Given this list of marker genes MMP12, ACY1, CAPN2, PLAU, ENPEP, FOLH1 (folate hydrolase 1), MMP10, CPA3, KLK6, CTSB, ACE, PRSS8, ADAM9, MMP13, FAP, CPN1, NAPSA, MMP7, PRSS2, F2, PEPD, CPM, CTSS, FURIN, TPSAB1, MMP15, CTSW, C2, CTSL, OLR1, GZMB, LAP3, GZMA, BMP1, CTSK, C1S, MMP11 (matrix metallopeptidase 11), PSMB9, CPB2 (NCBI Gene Id 81954), CTSC, C1R, TMPRSS2, PROC, HPN, CTSD, F12, GZMK, CELA3A, PGC, CTSE, CFB, CASP4, CASP1, MST1, HP, UBD, PLG (NCBI Gene Id 90749), MMP3, PRSS23, MMP9, HTRA1, XPNPEP1, PROZ, MMP2, APOC1, TIMP1, LGMN, ANPEP, F10, CTSO (cathepsin O), CFI, DPP4, WFDC2, AEBP1, MMP1, PLAT, KLK10, ADAM8, MMP14, here is a description of the gene set: studied in species Homo sapiens Genes in the cancer module 107. Human Gene Set: MODULE_107